The following is a description of a gene set: Mouse Gene Set: GOBP_NEGATIVE_REGULATION_OF_ALPHA_BETA_T_CELL_PROLIFERATION Any process that stops, prevents, or reduces the frequency, rate or extent of alpha-beta T cell proliferation. species: Mus musculus, and this is the list of marker genes: Ndfip1, Arg2, Tarm1, Vsir, Itch, Zbtb7b, Cd274, Slc4a2, Xcl1, Cblb (Casitas B-lineage lymphoma b), Foxp3, Lgals9, Twsg1, Tnfrsf14, Btla (NCBI Gene Id 436360), Clec4g, Cd44